The following is a description of a gene set: Mouse Gene Set: GOBP_XANTHINE_METABOLIC_PROCESS species: Mus musculus The chemical reactions and pathways involving xanthine, 2,6-dihydroxypurine, a purine formed in the metabolic breakdown of guanine but not present in nucleic acids., and this is the list of marker genes: Urad, Uox, Xdh, Ada, Urah